Given this list of marker genes Mas1, Secisbp2l, Fbrsl1, Arhgef12, Ankrd44, Col4a3, Ctsr, Plaur, Dpysl2, Idh1, Xiap, Ppp1r1c, Ube2i, Atp2b2, Cavin2 (caveolae associated 2), Cdh7, Abcb7, Thsd7a, Wdr33, Pax9, Gm2042, Ormdl1, Ccne2, Ogn, Smurf2, Magohb, Got2, Zfp558, Sptssa, Laptm4b, Actr2, Ppm1b, Tmem263, Naaladl2, Mbnl3, Tspan1, Igf1, Cdh6, Hdac8, Agpat5, Aga, Cables1, Ralgapb, Bmp3, Msl3, Fam120a, Nfil3, Fgfr4, Serpinb12, Myo5a (NCBI Gene Id 57374), Aox1, Nkd1, Macrod2 (mono-ADP ribosylhydrolase 2), here is a description of the gene set: Mouse Gene Set: MIR_5108 Genes predicted to be targets of miRBase v22 microRNA mmu_miR_5108 in miRDB v6.0 with MirTarget v4 prediction scores > 80 (high confidence targets). studied in species Mus musculus from publication Chen Y, Wang X (PMID 31504780)